The following is a description of a gene set: Mouse Gene Set: MARTINEZ_TP53_TARGETS_DN species: Mus musculus Squamous cell carcinomas (SCC) represent the most aggressive type of nonmelanoma skin cancer. Although little is known about the causal alterations of SCCs, in organ-transplanted patients the E7 and E6 oncogenes of human papillomavirus, targeting the p53- and pRb-dependent pathways, have been widely involved. Here, we report the functional consequences of the simultaneous elimination of Trp53 and retinoblastoma (Rb) genes in epidermis using Cre-loxP system. Loss of p53, but not pRb, produces spontaneous tumor development, indicating that p53 is the predominant tumor suppressor acting in mouse epidermis. Although the simultaneous inactivation of pRb and p53 does not aggravate the phenotype observed in Rb-deficient epidermis in terms of proliferation and/or differentiation, spontaneous SCC development is severely accelerated in doubly deficient mice. The tumors are aggressive and undifferentiated and display a hair follicle origin. Detailed analysis indicates that the acceleration is mediated by premature activation of the epidermal growth factor receptor/Akt pathway, resulting in increased proliferation in normal and dysplastic hair follicles and augmented tumor angiogenesis. The molecular characteristics of this model provide valuable tools to understand epidermal tumor formation and may ultimately contribute to the development of therapies for the treatment of aggressive squamous cancer. from publication Martínez-Cruz AB, Santos M, Lara MF, Segrelles C, Ruiz S, Moral M, Lorz C, García-Escudero R, Paramio JM (PMID 18245467) Genes down-regulated in mice with skin specific knockout of TP53., and this is the list of marker genes: Myh14, Mt1, Gas1, Smad4, Frmd4b, Igfbp4, Polr3a, Golga4, Marcksl1, Tenm2, Lsr, Cebpb, Krt82, Fzd7, Hnf4g, Kif1c, Cer1, Ppib, Grk4, Tenm4, Maml1, Krtap19-5, Tecr, Yipf4, Zcchc9, Sdhaf4, Atm, Rpl37, Clcn3, Edn3, Hmgb1, Ifi205, Safb2, Eprs1, Gip, Egln3, Ndufa3, Egfr, Hipk2, Neurod4, Rcc2, Arhgef25, Rrad, Cd248, Vamp8, Tuba4a, Ero1a, Vmn1r49, Pde3a, Uty, Clk1, Fzd6, Fhdc1 (NCBI Gene Id 229474), Col18a1, Plec, Wwc1 (NCBI Gene Id 211652), Mst1r, Huwe1, Smad1, Pmepa1, Spesp1, Col11a1, Ubqln4, Slc25a30, Atp2a2, Elovl3, Rarg, Rab6a, Ank3, Ptprf, Siva1, Egr2, Tjp2, Iapp, Cacfd1, Acsl5, Spint1 (serine protease inhibitor, Kunitz type 1), Aldh1a3, Mrtfa, Tomm70a, Dlx3, Slc25a10 (solute carrier family 25 (mitochondrial carrier, dicarboxylate transporter), member 10), Wdr75, Slc5a6, Mtrex, Efnb1, Rbbp4, Rhog, Clec10a, Pkp2, S100a14, Bmerb1, Prelp, Pcbp2, Foxc1, Csnk1d, Snrpg, A030005L19Rik, Rbbp8, Sephs2, Dct, Dynlt1b, Clns1a, Krt33b, Lpin1, Efna3, Rps7, Myh1, Actrt2, Krt79, Rassf3, Rpl34, Mki67, Rims2, Hoxa3, Nectin2, Ptgds, Ctsb, Plin4, Pgd, H2bc22, Ubl5, Krtap15-1, Pinlyp, Mif4gd, Slc39a6, Iffo2, Ecrg4, Tfdp1, Retreg3, Mrpl52, Ppp4r3b, Rbbp6, Sox9, Abca2, Polg, Dop1b, AI661453, Zfp36, Hacd2, Apba3, Taok1, Pdcd7, Tgs1, Pkdrej, Klk10, Uap1, Sox5, Krtap21-1, Edaradd, Krtap9-3, Crim1, Krtap8-1, Fryl, Atp11a, Fbn2, Lgals7, Hspa8, Dus1l, Hjurp, Eif4ebp1, Krtap9-1, Rps6, Srsf3, Erc1, Qki, Defb6, Krtap19-9b, Mgll, Sf3b2, Ly6g6d, Ltbp2, Hopx, Zmynd11, Msx2, Sf3a2, Numa1, Hsd17b11, Plxnb3 (NCBI Gene Id 56230), Car6, Stx18, Bicc1, Gdpd3, C1ra, Chek2, Mybl2, Prmt5, Krtap19-4, Brd3, Lasp1, Slc27a4, Ssbp2, Rhov, Rhbg, Nfe2l3, Sap18, Diaph3 (NCBI Gene Id 80466), Cryl1, Adipoq, Cdk2ap1 (cyclin dependent kinase 2 associated protein 1), Thra, Krtap12-1, Chac1 (ChaC, cation transport regulator 1), Col1a1, Lad1, Ubc, Cpt1a, Ddx3y, Chst1, Krt17, Ccnd2, Rtraf, Siah1a, Dnajc3, Riok2, Unc5b, Krt72, Sptbn2, Rhou, Epas1, Cct2, Wdr12, Basp1, Pigb, Bach2 (BTB and CNC homology, basic leucine zipper transcription factor 2), Krt75, Elovl6, Ccnl1, Slc7a5, Celf4, Enc1, Tnrc6a, Cyp17a1, Nhsl1, Naa12 (NCBI Gene Id 117903916), Cpsf4, Retnlb, Hmga1, Vdr, Lig3, Cops9, Gjb2, Pds5a, Slc39a14, Bach1, Ncdn, Mta1, Ccdc137, Krt31, Nfia, Rab4a, Npepl1, Purb, Prss12, Aatf, H2-K1, Fabp4, Lyar, Krtap5-25, Dlx1, Lce1h, Rpl3l, Smarcd2, Ddr1, Mis12, Zdhhc14, Ppcdc, Krt85, Dap, Rdh11 (NCBI Gene Id 97829), Ces4a, Mtf2, Pdap1, Rps17, Ripk4, Csf1r, Acvr2b, Fads3, Ptpn13, Polr2l, Trp53, Mrpl33, Impact, Wnt5a, Pfkfb3, Pmel, Crtc3, Krtap3-1, H2bc4, Snx30, Cenpa, Dkk2, Krtap19-3, Rnf149, Cebpg, Tle3, Krt81, Snca, Slc35a2, Calhm5, Atp5pd, Eftud2, Msh4, Krt12, Tmcc3, Celf1, Atp5if1, Ccnd1, Faap20, Sfrp2, Arl8b, Tspo, Pkig, Rps8, Myh3, Esrp1, Krtap6-7, Krtap28-13, Slc44a1, Ublcp1, Herc6, Slc39a11, S100a3, Atf7ip2, Clip4, Sh3rf1, Zfp280d, Mcl1, Flna, Meis2, Incenp, Npy, Virma, Rpl37a, Lce1i, Shisa2, Tardbp (NCBI Gene Id 97174), Canx, Nfib, Gprc5d, Timp3, Krtap16-3, Map4, Mga, Cdh3, Enox2, Eif3e, Trh, Man2b1, Myh6, Wrn, Ube2f, Krt23, Irx4, Krt27, Atxn7l3b, Acan, Pax6, Plk1, Padi3, Poldip3, Camk2b, Psors1c2, Aplp2, Krtap6-2, Rps18, Cxxc5, Rpl26, Dmd, Scmh1, Lama5, Dstyk, Pigq, Rtp4, Extl3, Rps24, Chd4, Rnaset2b, Rbfox2, Agpat1, Adamts4, Dpysl3, Agfg2, Supt6, Krtap19-1, Errfi1, Ndufa5, Nherf2, C1d, Grhl1, Ints6l, Ethe1, Map3k5, Cx3cr1, Sp110, Lsm12, Slc1a5, Tmem131l, Ilf3, Col9a3, Tmod2, Gna13, Nme7, Gm42047, Krt33a, Rps21, Ypel1, Rasl11b, Zfp574, Man2c1, Max, Ucp2, Pfn2, Tro, Cryba4, Ryr1, Dnph1, Smo, Pcolce (procollagen C-endopeptidase enhancer protein), Fa2h, Krtap13-1, Ggt1, Krt71, Aldh3a1, Krtap19-2, Nav2, Aff2, Eln, Ldhb, Riok3, ENSMUSG00000139502, Galr1, Trbv29, Foxp1, Ndufa2, Fgfbp1, Marcks, Shmt1, Trim2, Krtap1-5, Neo1, Cibar1, Krtap20-1, Scara3, Ube3a, Rmnd5b, Hras, Tfap2b, Ctnnal1, Os9, Slc35b1, Cald1, Cap1, Ppih, Plod2, Calr, Cdkn1a, Ece1, Krtap6-5, Atp6v0c, Mup1, Rab12, Lgr5, Mllt1 (NCBI Gene Id 64144), Pabpn1, Tg, Crym, G6pdx, Piwil2, Adgrg1, Krtap6-1, Xdh, Krt86, Krtap5-2, Ndel1, Lpcat1 (lysophosphatidylcholine acyltransferase 1), Ephx2, Myo10, Tex261, Atf1, Fhl2, Mrpl39, Rpl23, Tnmd, Gsdma, Kat7, Krt34, Pmfbp1, Idi1, Rpn2, Cdh5, Sox2, Hook2, Krt83, Sfxn3, Tpo, Pip5k1c, Aurkc, Pttg1ip, Krtap4-2, Cers4, Gstp2, Psmc4, Xpo5, Lypd8l, H2-D1, Srek1, Fubp1, Pank1, Mt4, Usp18, Lgals3bp, Mbp, Pkd1, Ammecr1l, Fkbp5, Mt2, Tnnt1, Mbd3l2, Igfbp2, Brd2, Mfap3, 1700091H14Rik, Edc4, Gabrp, Cwh43, Junb, Masp1, Parp3 (NCBI Gene Id 320721), Sntb2, Camkk2, Qng1, Prnp, Pip, Zfp148, Scyl1, Strbp, Xist, ENSMUSG00000125611, Lep, Rpl27, Krt25, Pou1f1, Phb2, Zdhhc5, Tc2n, Ctnnbip1, Gjb6 (gap junction protein, beta 6), Krt32, Krtcap2, Rpl14, Tcf20, Upp1, Itpr3, Bbip1, Ephx1, Sprr1a, Rhbdl3, Ap4s1, Igdcc4, Baalc, Gclc, Apoe, St14, Actn3, Tchh, Wrap73, Gtf2b, Notch1, Kera, Srrm1, Hacd4, Kdm5b, Cyp2g1, Ptpre, Plcb1, Krtap9-22, Col6a2, Gnmt, S100a10, Plxna2, Bhlha15, Fgf7, Aqr, Celsr2, Krtap6-3, Gm12617, Hr (lysine demethylase and nuclear receptor corepressor), Pigu, Hmgcs1 (3-hydroxy-3-methylglutaryl-Coenzyme A synthase 1), Pdk4, Bcr, Tmed10, Sult2b1, Usp19, Patz1, 5033421B08Rik, Rpl21, Ovol1, Foxo1, Tor2a, A030005K14Rik, Fxyd4, Thrap3, Pam16, 2510002D24Rik, Fkbpl, Hhip, Ints9, Ctns, Krtap4-16, Cux1, Krtap4-13, Slurp1, Timp1, Dnajc17 (DnaJ heat shock protein family (Hsp40) member C17), Nkd2, Homer2, Aars1, Gsk3b, Nr2f1, Pom121, Wfdc21, Krt35, Fbp1, Abce1, Krt36, Smarca4, Clu, Tpr, Krtap14, Bambi, Fastkd2, Son, Polr2a, Kmt5a, Scaf11, Glipr1l2, Clpb